Given this list of marker genes DOCK2, nef, RAC1, ELMO1, CD247, LCK, PAK2, FYN, HCK, here is a description of the gene set: Reactome Pathway: Nef and signal transduction part of: The role of Nef in HIV-1 replication and disease pathogenesis Nef interferes with cellular signal transduction pathways in a number of ways. Nef is associated with lipid rafts through its amino-terminal myristoylation and a proline-rich SH3-binding domain. These cholesterol-rich membrane microdomains appear to concentrate potent signaling mediators. Nef was found to complex with and activate serine/threonine protein kinase PAK-2, which may contribute to activation of infected cells. In vitro, HIV-infected T cells produce enhanced levels of interleukin-2 during activation. When expressed in macrophages, Nef intersects the CD40L signaling pathway inducing secretion of chemokines and other factors that attract resting T cells and promote their infection by HIV. studied in species Homo sapiens